Given this list of marker genes Sik2, Cox11, Gckr, Sirt6, Mup5, Ins1, Flcn, Grb10, Midn, Serpina12, Lepr, Nupr1, Ins2, C1qtnf3, Ap2a1, Ppp1r3b (NCBI Gene Id 330736), Prkaca, Erfe, Tigar, Mup1, Cbfa2t3, Prkag3, Sik1, Mup2, Adipoq, Ddit4, Ep300, Pask, Prkn, Adra1b, Tgfb1, Usp7, Fbp1, Mst1, Gck, Plek, Actn3, Mup11, Gpi1 (glucose-6-phosphate isomerase 1), Mtch2, Enpp1, Mup3, 1810024B03Rik, Slc4a1, Gfpt1, Inpp5k, Stat3, Pfkfb1, Kat2a, Hdac4, Ncor1, Tcf7l2, Ier3 (NCBI Gene Id 15937), Slc25a12, Trim63, Xpc, Obp2a, Mup4, Ppara, C1qtnf12, Git1, Gsk3b, Ppp2ca, Prkg1, Mtcl2, Ppargc1a, Pgp, Myog, Smpd3, Il6, Clk2, Cry1, Cltc, Trp53, here is a description of the gene set: species: Mus musculus Mouse Gene Set: GOBP_NEGATIVE_REGULATION_OF_CARBOHYDRATE_METABOLIC_PROCESS Any process that stops, prevents, or reduces the frequency, rate or extent of the chemical reactions and pathways involving carbohydrate.